The following is a description of a gene set: We explored whether the five previously reported molecular subtypes in breast cancer show a preference for organ-specific relapse and searched for molecular pathways involved. The intrinsic gene list describing the subtypes was used to classify 344 primary breast tumors of lymph node-negative patients. Fisher exact tests were used to determine the association between a tumor subtype and a particular site of distant relapse in these patients who only received local treatment. Modulated genes and pathways were identified in the various groups using Significance Analysis of Microarrays and Global Testing. Bone relapse patients were most abundant in the luminal subtypes but were found less than expected in the basal subtype. The reverse was true for lung and brain relapse patients with the remark that absence of lung relapse was luminal A specific. Finally, a pleura relapse, although rare, was found almost exclusively in both luminal subtypes. Many differentially expressed genes were identified, of which several were in common in a subtype and the site to which the subtype preferentially relapsed. WNT signaling was up-regulated in the basal subtype and in brain-specific relapse, and down-modulated in the luminal B subtype and in bone-specific relapse. Focal adhesion was found up-regulated in the luminal A subtype but down-regulated in lung relapse. The five major molecular subtypes in breast cancer are evidently different with regard to their ability to metastasize to distant organ(s), and share biological features and pathways with their preferred distant metastatic site. Human Gene Set: SMID_BREAST_CANCER_ERBB2_DN Genes down-regulated in the erbb2 subype of breast cancer samples, characterized by higher expression of ERBB2. from publication Smid M, Wang Y, Zhang Y, Sieuwerts AM, Yu J, Klijn JG, Foekens JA, Martens JW (PMID 18451135) studied in species Homo sapiens, and this is the list of marker genes: NPY1R, SOX10, PMAIP1, GABRP, FGFR2